The following is a description of a gene set: Small nail studied in species Homo sapiens A nail that is diminished in length and width, i.e., underdeveloped nail. Human Gene Set: HP_SMALL_NAIL, and this is the list of marker genes: HEPHL1, PIGO, IGF2, METTL27, KMT2D, GTF2IRD1, PIGW, TRRAP, KRT5, CENPT, PIGF, CPT2, BICRA, EOGT, OTUD5, IKBKG (inhibitor of nuclear factor kappa B kinase regulatory subunit gamma), INPPL1, ARHGAP31, LIG4, EVC, ERCC2, DLK1, ZFX, NOP10, DPF2, EVC2, TCTN3, ZIC3, DNAJC21, ALOX12B, TP63, ROR2, ALG3, STX1A, SIAH1, PIGV, APC2, SOX4, SHANK3, ALOXE3 (NCBI Gene Id 64048), SUZ12, EIF5A, PLAG1, CCDC22, UBAP2L, TFAP2A, HYMAI, DYNC2LI1, COL11A1 (collagen type XI alpha 1 chain), MLXIPL, RSPO1, EBF3, TWIST1, ARID1A, BHLHA9, TSPAN7, PTDSS1, PRR12, RLIM, DPYSL5, PGAP3, EIF4H, VPS35L (NCBI Gene Id 57020), POP1, NCF1, NSD1 (nuclear receptor binding SET domain protein 1), WNT10A, FBXO28 (F-box protein 28), CDIN1, TBX4, WDR73, PPP2R5D, STAMBP, BAZ1B, KCNH1 (potassium voltage-gated channel subfamily H member 1), GLI1, SOX11, HMGA2, PIGN, ZNF462, NHP2, HUWE1, AFF4, PRKACB, GDF5, PLEC (NCBI Gene Id 5339), TMEM270, COL11A2, TOMM7, ODC1, SMARCAD1, FOSL2, ALG12, PIGA, MBTPS2, MPLKIP, NEPRO, NECTIN4 (NCBI Gene Id 91969), PIGY, ARID2, RTL1, WLS, SHOX, FRAS1, ELN, HOXA13, PGAP2, SLC35D1, BMPER, KCNN3, EED, LIMK1, CWC27, ATP6V1B2, PEX2, NSUN2, ZMYM2, PIGL, SCO2, TWIST2, FGFR2, SET, GJB6, RAF1, SHOC2, POLR3A, DPH1, NOTCH1, DPH2, CKAP2L, SLC25A24, RERE, ARID1B, PIGB, GPC3, NSDHL, PLAGL1, CLIP2, EZH2, VPS37D, WASHC5, RFC2, MCTP2, SPEN, FTO, SMARCE1, ADAMTSL2, BUD23, IHH, POLR1A, PPM1D, PRKACA, TELO2, SMARCC2, GTF2I, ERI1, RIPK4, DNAJC30, SMARCB1, CDH1, SMARCA4, CDKN1C, RPS6KA3, DLL4, MSX1, KIF15, HRAS, FGFR1, COL7A1, KDM1A, HOXC13, ACTL6B, TMEM222, FKBP6, POC1A, RBPJ, TBC1D24, DOCK6, GTF2IRD2, DHX37, TBL2, MEG3, SMARCD1, TBX3, PPP1CB, GPC4